The following is a description of a gene set: species: Homo sapiens Human Gene Set: WP_HISTONE_MODIFICATIONS Histone modifications, and this is the list of marker genes: PRDM2, H3C10, EHMT1, NSD1, EHMT2, H3C11, H4C9, H4C12, H4C3, H4C7, KMT5C, H3C4, SETD5, SMYD1, H3C1, SMYD4, SET, H4C11, H4C4, SETD2, EED, SETMAR, H4C8, EZH1, SETDB2, SUV39H1, H4C2, SETD7, AEBP2, H3C15, H3-3A, H4C6 (H4 clustered histone 6), SMYD5, SETD1A, KMT5B, H3C12, SMYD3, SETBP1, KMT2E (NCBI Gene Id 84147), H3C13, KMT2D, SETD9, H3C6, SUV39H2, H4C1, H3-3B, ASH1L, H3C14, SETDB1 (SET domain bifurcated histone lysine methyltransferase 1), SETD4, SETD6, H3C7, SETD3, SETD1B, KMT2A, DOT1L, KMT5A, KMT2B, EZH2, H4C13, H4C16, H4C5, KMT2C, SMYD2, H3C8